Given this list of marker genes Ehmt2, Hat1, Hdac1, Hdac2, Ehmt1, here is a description of the gene set: Mouse Gene Set: WP_HISTONE_MODIFICATIONS Histone modifications species: Mus musculus